The following is a description of a gene set: species: Homo sapiens Human Gene Set: KEGG_MEDICUS_VARIANT_MUTATION_ACTIVATED_KCNJ5_TO_ANGIOTENSIN_ALDOSTERONE_SIGNALING_PATHWAY Mutation-activated KCNJ5 to angiotensin-aldosterone signaling pathway. Pathway ID: N00303. Pathway type: Variant. Pathway class: nt06316 Renin-angiotensin-aldosterone signaling. Pathway Definition from KEGG: KCNJ5* -> Na+ -> (CACNA1D,CACNA1H) -> Ca2+ -> CALM -> CAMK -> CREB => CYP11B2 -> Aldosterone, and this is the list of marker genes: ATF4 (NCBI Gene Id 468), CREB3L2, CREB5, CREB3, CALM1, CAMK2B, CAMK4, CREB3L1, CAMK1D, KCNJ5, CALM2, CAMK1G, ATF6B, CYP11B2, CAMK2G, CREB3L3, CACNA1H, CAMK2D, CREB1 (NCBI Gene Id 1385), CAMK1, CACNA1D, CAMK2A, CALM3, CREB3L4, ATF2